The following is a description of a gene set: Typically de novo Human Gene Set: HP_TYPICALLY_DE_NOVO studied in species Homo sapiens Description of conditions that are exclusively or predominantly observed to display de novo variants. In some cases, this may be due to the limited reproductive fitness of affected individuals., and this is the list of marker genes: CHD8, EIF2AK1, PIK3R2, GNB2, SEMA6B, ZBTB7A, ATP11A, MAPK1, PIK3CA, ATN1, KMT2C, POLR2A